The following is a description of a gene set: Human Gene Set: REACTOME_NETRIN_MEDIATED_REPULSION_SIGNALS species: Homo sapiens Netrin mediated repulsion signals, and this is the list of marker genes: UNC5A, UNC5D (NCBI Gene Id 137970), DCC, PTPN11, SRC, NTN1, UNC5C, UNC5B